Given this list of marker genes Slc2a4, Dnm2, Ap3d1, Dnm3, Ap3s1, Dnm1, Ap3m2, Ap3b2, Ap3s2, Mx2, here is a description of the gene set: species: Mus musculus Evagination of the presynaptic membrane, resulting in the formation of a new synaptic vesicle. Mouse Gene Set: GOBP_SYNAPTIC_VESICLE_BUDDING_FROM_PRESYNAPTIC_ENDOCYTIC_ZONE_MEMBRANE